Given this list of marker genes Septin2, Ano2, Cetn3, Opn1sw, Myo3b, Enkd1, Pkhd1, Arr3, Rac1, Cep290, Whrn, Pip4k2a, Ift20, Nxnl1, Pde6b, Pcare, Prph, Iftap (intraflagellar transport associated protein), Tubg1, Cdhr1, Phlpp2, Prom1, Arl13b (ADP-ribosylation factor-like 13B), Drd5, Plekhb1, Gngt1, Strc, Ccdc66, Kifap3, Pde6a, Mlf1, Ift122 (NCBI Gene Id 97320), Ift57, Pcdh15, Ift80, Pkd1l1, Rom1, Gpr83, Grk1, Rp1, Arl13a, Cnga4, Cetn2, Pgr15l, Dnaaf4, Nup42, Ptgs1 (NCBI Gene Id 19224), Rsph9, Mertk, Hyls1, Cetn1, Rdh11, Prph2, Ush2a, Tbcc, Bbs4, Tulp3, Magi2, Fam161a, D630045J12Rik, Pkd2l1, Npy2r, Cngb1, Crb1, Ttll7, Smo, Galr3, Myrip, Pkd2, Mchr1, Rab8a, Cnga3, Mdm1, Pcdhb16, Drd1, Nphp1, Ocrl, Ttll5, Myo5a, Ift88, Bsg, Rab27a, Elmod3, Tsga10ip, Sdccag8, Rcvrn, Rho, Tulp1, Cdc14a, Cfap410, Drd2, Rpgrip1, Prcd, Guca1b, Sptbn5 (spectrin beta, non-erythrocytic 5), Map1a, Opn3, Ift140, C130074G19Rik, Gnat2, Sag, Gnat1, Septin9, Rapgef4, Pde6g, Ptprk, Prkca (NCBI Gene Id 18750), Adgrv1, Cep89, Myo7a, Hnf1a, Kif3a, Inha, Mak, Topors, Tmem237, Ttc8, Nphp4, Ush1c, Cfap96, Qrfpr, Glis2, Cfap69, Pdc, Spata7, Dynll2, Cdh23, Ttll6, Rpgr, Cacna1f, Gucy2d, Mkks, Vcan, Wdr19, Guca1a, Ttll4, Bbs7, Opn1mw, Impg1, Cnga1, Gucy2e, Pex6, Lca5, Iqcb1, Slc24a4, Cngb3, Cib2, Erich3, Dcdc2a, Alpk1, Ift52, Rpgrip1l, Rd3, Pcdhb22, Ush1g (NCBI Gene Id 217309), Abca4, Cerkl, Gucy2f, Ahi1, Opn5, Cep250, Stx3, Sstr3, Atp1a4, Lyar, Phyh, Arl3, Map1b (NCBI Gene Id 268696), Tiam1, Pafah1b1, Cnga2, Kif17, Kncn, Pde6h, Grxcr1, Poc5, Rp1l1, Gnb1, Shank2, here is a description of the gene set: Mouse Gene Set: GOCC_NON_MOTILE_CILIUM species: Mus musculus A cilium which may have a variable array of axonemal microtubules but does not contain molecular motors.